Given this list of marker genes IQCH, ZNF606, CHRM1, DNAH7, IGSF9, PSEN1, CDH20, IL15RA, CDH7, CDKL3, RASSF6, TLR8, HCN1, C19orf44, EXOC6B, SMIM6, FCAMR, GSTT1, RBM24, GRID2, CCDC63, ZNFX1, PADI1, MDH1B, LRRC3B, DENND2D, CHD8 (chromodomain helicase DNA binding protein 8), DLK1, CYP2J2 (NCBI Gene Id 1573), NHSL3, TLR5, CA11, FSHR, GPR75, ZHX2, DNAH17, CCDC54, RGMB, PABPC5, ZNF397, DPYS (NCBI Gene Id 1807), GPX6, PRM3, USP42, CEACAM20, ACCSL, SLC2A13, RIPPLY3 (NCBI Gene Id 53820), MCCC1, VAT1L, TMT1B, SH3RF3, GCNT2, HIC1, PPIL6, TMEM52, CCER1, GPT2, MID2, KCNB1, SCN3B, SLAMF9, FAM184A, NECAB2, GUCA1A, FAM90A13, CORO2B, PTGDS, HS3ST2, CYP4A22, SLC22A25, GPR4, RNF180, COL4A2, RBP3, OTC, FASLG, SLFN12, HRH1, LRP2BP, PLEKHS1, TRH, KLF12, SERPINB11, TMEM207, MYO1H, C6orf58, BACE2, EREG, TNFAIP6, SYT13 (NCBI Gene Id 57586), DMRT2, OR51B4, PCDHB1, ARHGEF9 (Cdc42 guanine nucleotide exchange factor 9), NELL1, ZNF354B, ZBTB8B, KCNQ1, DDR2, RSPO3, ASIC4, SPTBN2, THBS3, TYR, BMF, CCNB3, BCAR3, SLC16A9, OBP2B, URGCP, PLEKHA6, CD83, HIVEP2, CD70, MYOF, MAPK10, PHACTR3, PER3, CLIP3, CDCP1, SH3GL3, CCN1, SLC10A1 (solute carrier family 10 member 1), RNASE1, SHC3, FAM110B, BDKRB1, SMC1B, ST8SIA2, CSF2, HAVCR1, THEM4, SYNDIG1, TMC1, YAP1, KCTD15, TRPC5, UNC13A, PLD1, ZNF81, LONRF2, RGS1, SMARCA1, MAP7D2, STK39, CCDC38, A1CF, LAMC3, CABYR, ZBTB8A, CFAP91, HSD3B1 (NCBI Gene Id 3283), CYLD, RBFOX3, ABCC1, ZFP28, ZYG11A, CETN2, CASR, LRRN4CL (NCBI Gene Id 221091), HMGCLL1, MMP19 (NCBI Gene Id 4327), TPK1, ARHGAP28, CYP2U1, SEMA3C, TEX15, FOXJ2, INPP5A, SLC1A1, CYP2R1, SNED1, MOGAT2, GPLD1, WNT16, ISX, ARK2N, IL27RA, PLEKHG1, TMEM202, HERC6, SMOC1, HSPA1L, IL4R, ARHGAP6, SLITRK4, TENM2, CCNL1, SPRR3, TSPAN9, RSPH4A, ST6GALNAC5, EPB41L1, NYAP1, SLC25A2, CERKL, ATP6V0A4, EPHA6, CLCN5, here is a description of the gene set: from publication Yusuf I, Kageyama R, Monticelli L, Johnston RJ, Ditoro D, Hansen K, Barnett B, Crotty S (PMID 20525889) studied in species Homo sapiens Genes down-regulated in CD4 follicular helper T cells (Tfh) versus non-Tfh. CD4 T cell help is critical for both the generation and maintenance of germinal centers, and T follicular helper (TFH) cells are the CD4 T cell subset required for this process. SAP (SH2D1A) expression in CD4 T cells is essential for germinal center development. However, SAP-deficient mice have only a moderate defect in TFH differentiation as defined by common TFH surface markers. CXCR5+ TFH cells are found within the germinal center as well as along the boundary regions of T/B cell zones. Here we show that germinal center associated T cells (GC TFH) can be identified by their co-expression of CXCR5 and the GL7 epitope, allowing for phenotypic and functional analysis of TFH and GC TFH populations. Here we show GC TFH are a functionally discrete subset of further polarized TFH cells, with enhanced B cell help capacity and a specialized ability to produce IL-4 in a TH2-independent manner. Strikingly, SAP-deficient mice have an absence of the GC TFH subset and SAP- TFH are defective in IL-4 and IL-21 production. We further demonstrate that SLAM (Slamf1, CD150), a surface receptor that utilizes SAP signaling, is specifically required for IL-4 production by GC TFH. GC TFH cells require IL-4 and IL-21 production for optimal help to B cells. These data illustrate complexities of SAP-dependent SLAM family receptor signaling, revealing a prominent role for SLAM receptor ligation in IL-4 production by germinal center CD4 T cells but not in TFH and GC TFH differentiation. Human Gene Set: GSE21379_TFH_VS_NON_TFH_CD4_TCELL_DN